The following is a description of a gene set: species: Homo sapiens Human Gene Set: GSE5099_UNSTIM_VS_MCSF_TREATED_MONOCYTE_DAY3_DN from publication Martinez FO, Gordon S, Locati M, Mantovani A (PMID 17082649) Monocytes mature tom acrophages in the presence of the lineage determining cytokine M-CSF. They can be further polarized into M1 or M2 macrophages with distinct functional properties. We used microarrays to detail the global programme of gene expression underlying macrophage maturation and polarization and identified distinct classes of up-regulated genes during this process. Genes down-regulated in monocytes: untreated versus CSF1 knockout at day 3., and this is the list of marker genes: NXPE4, SCP2D1, IER2, DOT1L, UNC5B, FEZF1, ACO2, LYNX1, TANC1, COL19A1, KLF7, EBI3, ULK3, MINDY1, MTPN, TWF2, NODAL, SNX12, SLN, S100A4, C14orf180, RHBDF1, ENO3, ARMC5, SLC25A39, LRRC8C, HAGH, VASP, NRROS, ZNRF1, OPA3 (outer mitochondrial membrane lipid metabolism regulator OPA3), PRPSAP1, S100A6, WDR6, WWC1, TPM3, AAGAB, TOLLIP, EIF4B, ARPC4, SNED1, CELSR1, BAG3, PUM1, EIF3I, PDXK, IFNGR1, TLE1, UBAP2L, CNBD2, NAA60, ZNF346, TLE3, MAP2K7, SGSH, DLG2, ADM, ACOT7, FASN, PHF2, FOXJ2, FSCN1, NFKB1, ARL2BP, WASHC2A, PROCR, SERTM1, TUBA1A, PYGB, ZNF414, NCOR2, KIAA0319L, MTHFSD, TCOF1, LNX2 (NCBI Gene Id 222484), CLASP1, MRPL28, TUSC1, GSK3A, DUSP11, MIB2, PARN, LRP1B, VARS1, VWA2, KDR, SART1, AHNAK2, METTL26, D2HGDH, ANKRD13D, VPS35L, BLTP2, HLA-DOB, CRLF2, EEF2K, ZCCHC17, PIEZO1, PAK1, GPR25, SELPLG, GGA1, FHOD1, MYO1G, PABPN1 (poly(A) binding protein nuclear 1), ADAM11, NPLOC4, MICAL1, C17orf50, CTDSP2, SLC15A3, PRG2, ARHGAP39, TTC7A, SH3BP1, PRKAR1A, TNK2, GRAMD4 (GRAM domain containing 4), NSF, BLOC1S4, TRIM27 (tripartite motif containing 27), PIGL, WDR5, STX6, RGS7BP, FOS, SNAP47, KLF6, ASIP, TRIO, TOMM34, CSRNP1, SUMO3, PKP4, SLC39A12, SLC25A51 (solute carrier family 25 member 51), CASS4, NEURL1B, ECE1, USP49, CDIPT, TSEN34, TBC1D9B, AKNA, HLA-B, POLD2, ACVR1B, ENSA, PPP2R1A, TSPO, CHST15, ARK2C, ALKBH6, PLCL2, HCK, FERMT3, ATP6AP1, ZYG11A, CCND1, H2AX, AVPI1, ANXA6, XPO6, MSL1, MXD1, SUMF2, RAB43, SIAH1, POLRMT, CD22, PRRC2B, ARHGEF2, MAP2K3, MAP2K2, CRTAP, ZNF608, CSNK1D, TNS3, EIF4G1, DCAF7, PLBD1, API5, ABCG1, TKT, ZNF710, SMIM3, NAGK, TBCC, TP53BP1, GPRASP2, PADI2, EPS15L1, IPO13, CS, IMP3 (NCBI Gene Id 64970), SNIP1, C1orf198, MARVELD1, P2RX6, RAMP3